The following is a description of a gene set: species: Mus musculus The chemical reactions and pathways resulting in the formation of an isoprenoid compound, isoprene (2-methylbuta-1,3-diene) or compounds containing or derived from linked isoprene (3-methyl-2-butenylene) residues. Mouse Gene Set: GOBP_ISOPRENOID_BIOSYNTHETIC_PROCESS, and this is the list of marker genes: Pdss2, Aldh1a1, Coq2, Crppa (NCBI Gene Id 75847), Idi1, Dhrs9, Mvd, Hmgcs2, Idi2l, Rdh19, Cyp1a1, Mvk, ENSMUSG00000144291, Rbp1, Akr1c18, Fdft1, Aldh1a2, Hmgcr, Rdh1, Hmgcs1, Idi2, Idi1-ps1, Aldh8a1, Rpe65, Srd5a3, Pex5, Dhdds, Rdh10, Fdps, Aldh1a3, Rdh16, Rdh9, Pmvk, Prmt3, Rdh16f2, Ggps1, Nus1, Lss, Pdss1